The following is a description of a gene set: Genes down-regulated in B16 melanoma at day 7 of adoptive transfer treatment: mock versus therapy. species: Homo sapiens Myeloid-derived cells comprising the tumor stroma represent a heterogeneous population of cells critical to the structure, function and growth of established cancers. We have recently found that engineering tumor-specific CD8+ T cells to secrete IL-12 (IL-12TD) can lead to striking improvements in T-cell activity against established melanomas in murine models. Surprisingly, IL-12-dependent enhancement of CD8+ T-cell anti-tumor function did not occur through direct ligation of receptors on lymphocytes or NK cells. Instead, IL-12 sensitized host bone marrow-derived tumor-stromal cells, partly through interferon-gamma, to indirectly enhance the effects of adoptively-transferred T cells. Direct presentation of antigen by tumor was not necessary, but MHC class I expression on endogenous cells was essential for IL-12 mediated anti-tumor enhancements. Upon successful treatment with IL-12TD cells, we observed the selective elimination of tumor-infiltrating CD11b+ F4/80+ macrophages, CD11b+/ClassII+/CD11c+ dendritic cells and CD11b+/Ly6C+/Ly6G- but not CD11b+/Ly6C+/Ly6G+ myeloid-derived suppressor cells within regressing lesions. These results are consistent with a model whereby IL-12 triggers the maturation of myeloid-derived cells into competent antigen cross-presenting cells. Licensed recognition of these antigens by effector T cells may in turn trigger the collapse of the tumor stroma and aid in the regression of large vascularized lesions. Human Gene Set: GSE29164_CD8_TCELL_VS_CD8_TCELL_AND_IL12_TREATED_MELANOMA_DAY7_DN from publication Kerkar SP, Goldszmid RS, Muranski P, Chinnasamy D, Yu Z, Reger RN, Leonardi AJ, Morgan RA, Wang E, Marincola FM, Trinchieri G, Rosenberg SA, Restifo NP (PMID 22056381), and this is the list of marker genes: AK2, MGAT2, IARS1, CD38, SEC61G, ANXA3 (annexin A3), ZNF747, UNC5B, RCBTB2, RRM2, LINC00486, CELP (NCBI Gene Id 286309), PRSS2, NME1, NOL7, SRGN, KDELR3, TRIB1, CEP128, FNDC3A, TMEM70, IGKV1D-13, ANKRD37, ACRV1, TYMS, C16orf46, SSR4, SPRR1A, SPINK13, RHOB, ANKRD30A, LILRB4, TCF12-DT, PPCDC, LAMP5, CRISPLD2, RGSL1, NUS1, TRAM1, MTFR1, CAV1, VASH2, SLC37A3, FARSB, CYTIP, TEDDM1, GMPPB, MANF, SLC1A4, SLC39A9, GGH, PRDX4, OSTC, CDCA5, CFAP107 (NCBI Gene Id 93190), CNKSR1, PSAT1, SSR2, TM4SF18, CENPE, SLCO4A1-AS1 (NCBI Gene Id 100135777), ILDR1, HSP90B1, APELA, RPN1, LGMN, SRPRA, MRPL10, MGLL, GPRC5D, ARMC2, CHPF, EIF2S2, SLC44A1, PRDM14, SLC66A1LP, TMEM74B, KRTAP9-4, IGLV3-19, GRASLND, RAB26, H3C10, PDIA4, FKBP11, IFI27L1, SELENOS, ZC2HC1B, SSR3, SEC61B, AKR1C1, MYBL2, MRPS22, PIK3CG, HESX1, SFXN1, UTF1 (NCBI Gene Id 8433), YARS1, BIK, ZWINT, PSMA5, HIGD1A, JCHAIN, CHAC2, SCG5, LGALS14, MYDGF, PTTG1, CFAP100, CHRM2, LAMP2, KCNJ16, FGF14 (fibroblast growth factor 14), PTCH2, FNDC3B, MYO7A, KDELR2, E2F6, FAM13A, SLC11A2, CYP2A7, CLDN18, SYT13, PDIA5 (NCBI Gene Id 10954), NANS, IGLL3P, TK1, ACOXL, IGLJ3, XBP1, PCLAF, SIL1, HYDIN, NTRK3, MZB1, EIF5B, GGT1, PRDM7 (NCBI Gene Id 92805), ZNF195, UCHL1, MAN1A1, IFITM1, ZNF334, QRFPR, STT3B, ERP44, MASTL, SLC35B1, LDHA, CCR2, FAM98A, ELMO1, COPB2, LRRC59, IGFBPL1, NRK, SPCS1, PKD2, PHF19, CCDC160, OIP5, SGPP2, CALML4, TMEM258, CYTOR, EHD4, HJURP, GAS6, ZNF35, OR7E36P, MOXD1, SDC1 (NCBI Gene Id 6382), SEC11C, ABRACL, CEP15, UAP1, CDK10, SAGE1, TRIP13, ADA, TEDC2-AS1, RWDD2B, GREB1L, RGS13, RDH12, SEC13, STKLD1, KRTAP19-1, EIF2AK2, VSTM2A, ALG5, HSPA5, TSHB, GAB1, CREB3L2 (cAMP responsive element binding protein 3 like 2)